The following is a description of a gene set: species: Homo sapiens Proteins carrying a heparan sulfate (HS) chain are called heparan sulfate proteoglycans (HSPG). Free HS is usually stored within the secretory granules of mast cells or cleaved from HSPGs on degradation. HS is a member of the glycosaminoglycan (GAG) family and consists of the variably sulfated repeating disaccharide units heparan (Ido-GlcNAc) or heparosan (GlcA-GlcNAc). Higher degrees of sulfation and iduronic acid content in the polysaccharide chain confers the name heparin rather than heparan sulfate to the chain. Two or three HS chains attach to a core protein on the cell surface or in the extracellular matrix (Sasisekharan & Venkataraman 2000). HS bound to a core protein can regulate many biological processes such as angiogenesis, blood coagulation and tumour metastasis (Stringer & Gallagher 1997, Tumova et al. 2000). Degradation of HS is required to maintain a natural turnover of GAGs. Defects in the degradative enzymes result in lysosomal storage diseases, where GAGs build up rather than being broken down and having pathological effects (Ballabio & Gieselmann 2009). Reactome Pathway: Heparan sulfate/heparin (HS-GAG) metabolism part of: Glycosaminoglycan metabolism, and this is the list of marker genes: NDST3, IDUA, HSPG2, HS6ST1, SDC2, CTSL, EXT2, NDST4, SLC35D2, HS3ST4, GPC5, HS2ST1, HGSNAT, GPC4, GPC1, NAGLU (N-acetyl-alpha-glucosaminidase), HS3ST3A1, HS6ST3, EXT1, EXTL2, GLCE, HS3ST6, HPSE, NDST2, SGSH, HS3ST2, GPC3, HS3ST1, GPC6, GPC2, SDC1, AGRN, HS6ST2, IDS, EXTL3, SDC4, HS3ST5, HS3ST3B1, HPSE2, SDC3, NDST1